Given this list of marker genes Ripply2, Wnt3a, Fgf8, Lfng, Notch1, Dll1 (NCBI Gene Id 13388), Hes1, Tbx6, Epha4, Mesp2, here is a description of the gene set: Gene regulatory network modelling somitogenesis species: Mus musculus Mouse Gene Set: WP_GENE_REGULATORY_NETWORK_MODELLING_SOMITOGENESIS